The following is a description of a gene set: studied in species Homo sapiens Human Gene Set: GOBP_POSTSYNAPTIC_SPECIALIZATION_ASSEMBLY The aggregation, arrangement and bonding together of a set of components to form a postsynaptic specialization, a region that lies adjacent to the cytoplasmic face of the postsynaptic membrane., and this is the list of marker genes: PTK2B (NCBI Gene Id 5748), GAP43, NRXN1 (neurexin 1), CASKIN1, C1QL3, LRRC4B, SHANK3, NRXN2, FGFR1, CBLN1, NTNG2, CSMD2, ZDHHC12, NPTX1, ABI3, ABL1, SLITRK3, LATS1, LRRTM2, C1QL2, LRFN1, CRIPT, IL1RAP, SPTBN2, CRK, RELN, CRKL, PTEN, ARHGEF9, NLGN2, PRICKLE1, PTPRS, NTRK3, GRID2, LRFN4, PTPRD